The following is a description of a gene set: In the present study we used Affymetrix oligonucleotide microarrays to produce gene transcription profiles for the major leukocyte types in humans. This comprehensive dataset enabled us to not only establish which genes were expressed in each leukocyte type, but also which genes were expressed in each subset after activation. The used of a comprehensive dataset of gene profiles from all the major human leukocyte subsets enabled a novel and powerful means for identification of genes associated with single leukocyte subsets, or different immune paradigms. from publication Jeffrey KL, Brummer T, Rolph MS, Liu SM, Callejas NA, Grumont RJ, Gillieron C, Mackay F, Grey S, Camps M, Rommel C, Gerondakis SD, Mackay CR (PMID 16474395) Genes down-regulated in comparison of effective memory CD4 T cells versus central memory CD4 T cells. species: Homo sapiens Human Gene Set: GSE3982_EFF_MEMORY_VS_CENT_MEMORY_CD4_TCELL_DN, and this is the list of marker genes: PHF10, CASC3 (CASC3 exon junction complex subunit), HRC, KIR2DL2, PFN2, SEPTIN7P11, CERS6, BACH2, SOD3, ZNF16, VNN2, ENGASE (endo-beta-N-acetylglucosaminidase), NES, TUFT1 (NCBI Gene Id 7286), PMS2P5, ATP1A1, EHHADH, FMO1, LUZP4, CDC40, UGP2, SMPX, SINHCAF, EPHA1, MALL (mal, T cell differentiation protein like), KLHL41, MAU2, MNAT1 (NCBI Gene Id 4331), YLPM1 (YLP motif containing 1), C14orf132, PEG10, EIF2B5, SLC9A5, OBI1, NET1, CSNK1E, GSTM3, IQCC, POU6F1, PPP6R1, E2F6, BLCAP, NUFIP1, ABCC1, FBRS, FAM120C (NCBI Gene Id 54954), TNFRSF4, PLEKHA5 (pleckstrin homology domain containing A5), AKR1C2, MX2, ACOXL (NCBI Gene Id 55289), IPCEF1, BCAS4, CRTAP (NCBI Gene Id 253263), SECISBP2, PRR14, ACSL6 (NCBI Gene Id 56972), LPCAT4 (NCBI Gene Id 91188), ZNF117, MUC2, AKAP13, IMPACT, APP, LMO3, MKRN1, SORL1, DAGLA, ITGA2, IGLL3P, ARMC1, KIF18A, TXK (NCBI Gene Id 7294), HMGCS1, PRPF19, ASNS, HDHD5, ZNF137P, LDLRAP1, TRAF5, SEPTIN10, CLMN, OTULINL (NCBI Gene Id 54491), RHOH, NFKBIL1, CCR7, CPLX2, KCNV1, TNS1, SCML1, ECHDC1, CHTOP, JRKL, PABPC3, DENND2D, OSGEP, RAP1GAP, APBA2, PHACTR2, SPATA6L, DPH2, SBNO2 (strawberry notch homolog 2), NLGN4X, ADD1, ERICH1, POLI, TRBV10-2, BCL9, ZSCAN18, KLF7, ZNF442, SH3BP4, ZNF571, ZCWPW1, MAP4K2 (NCBI Gene Id 5871), YIPF6, FABP1, SERPINA6, DVL1, PMP2, CAND2, HAX1, KCNQ1, GPR153 (G protein-coupled receptor 153), ANKZF1, ASTN1, H3C10, GPA33, C1S, TLL2, CBFA2T2, ADAM9, GSTM1, DENND2B, POLRMT, SH3BGR, GALR3, KLHL1, DIXDC1, UROS (uroporphyrinogen III synthase), KLF9, MSH2, BSCL2, IL6R, AP1M2, TRIM46, AREG (NCBI Gene Id 727738), SERPINA2, VTCN1, ICAM5, MYO5C, FBXO41, SEMA6A, LPAR2, KRT14, P2RX2, SELL, USP15, SDAD1, LDLRAD4, TRAK1, ECE1, DESI1, ANKRD2, TCEA2, UGT8, SMARCD3, UBIAD1, DGKQ (NCBI Gene Id 1609), ATM, FAM171A1, CCL27, RUFY3, TYRO3, AIF1, LGALS13, NACA4P, EPB41L2, PLCL1, LRRN3 (leucine rich repeat neuronal 3), BTRC, FBXW4P1, IRAK4, MEOX2, IL6ST, DIAPH3, ZNF862, FGFBP1, CEP170, CCDC170, LINC00667, TENM1, ANGPT2, CEP135, FCHSD2, STK38L, OR10H2, LMX1B, SARAF